Given this list of marker genes PLPP6, CHRNE (cholinergic receptor nicotinic epsilon subunit), PERP, MEP1A, EFCAB6, PRKD3, CTNNA1, SKAP2, KLRG1, CAMKMT, IGF2R, VEGFC, NPFF, MSR1, CLDN12, GFI1 (NCBI Gene Id 2672), SRGAP3, BICD1, RASSF4, OR51B4, REXO5, AQP2, CDKN2B, UBASH3B, OR8A1, HGD, CD244, ODR4, BSCL2, CD96, GATA6, RCN1, TMBIM1, ANXA1, ADRB1, STK17B, PXDC1, COL5A3, RASGRP1, MED7, GOLGA4, A1CF, LIN28A, ATP6V0B, RNF128, CDIPTOSP, SDCBP2, RHOQ, SLC52A3 (NCBI Gene Id 113278), PTGER4, SDK2, ASAH1, CMA1, LRRK1, TEP1, EPDR1, ITGA1, AMIGO1, PXYLP1, LINGO1, RETN, SMARCA2, FHIP1B, ARMC7, RNF148, FGF13, STYK1, CDKN1A, SFI1, DPYD, ITPRIPL2, ST14, SPATA2L, YPEL3, HSD3B1, E4F1, THY1, GPR34, ZBTB38, MOBP, ADGRG5, TMEM63A, OCIAD1, MYADM, YJEFN3, AHSG, YES1, GUCA2B, PRKAA2, GGH, RAB40B, LAPTM5, SERPINE2, CSF1, MGAT4A, FASLG, KCTD11, MFNG, PKP3, COX7A2L, CHIC1, PLEKHO1, ADAM8, TMEM26, PIK3R6, ITGAE, FAT1, BTG1, FCER1G, TMEM163, BCR, GRIA3, GSTT1, LPGAT1, COLEC11, EPAS1, HP1BP3, C19orf12, IPCEF1 (NCBI Gene Id 26034), TMEM140, PRR13, PIK3IP1, CHRNG, GZMH, ENTPD1, GIPC2, FIRRE, FGL2, HID1, DENND3, PTGS1, C4orf54, NECAP1, TFEC, SPESP1, RGS3, SLC22A12, INSYN1, PLCG1, ADAM15, ABI3, CCNG1, IGFBP5, LPP-AS2, ID2, ZEB2, CCR5, RAB12, RESP18 (NCBI Gene Id 389075), CREBRF, FILIP1, CYFIP1, GZMK, PISD, C15orf48, DMRTB1, CCDC106, PICALM, YPEL5, SFXN3, SPACA4, CD109, GNPTAB, CAMK2N1 (calcium/calmodulin dependent protein kinase II inhibitor 1), C9orf152, CD93, AGPAT4, PLIN2, GNG2, GDF11, CCL5, AP3M2, LYVE1, KCTD12, CPEB3, NDRG1, C6, MIR22HG, CITED4, CNRIP1, LIPI, CAPG, ADAMTSL4, TESK1, APOBR, PVT1, LDAF1, PURA, TMPRSS13, ZAP70 (NCBI Gene Id 7535), GLRX, ABCB1, ADCY7, FAXC, ACP3, CFLAR, KCNG1, CNR1, FLOT2, TP53INP2, here is a description of the gene set: Genes down-regulated in comparison of splenic primary CD8 effector T cells at day 8 post-chronic infection versus splenic secondary CD8 effector T cells at day 8 post-chronic infection. Human Gene Set: GSE30962_PRIMARY_VS_SECONDARY_CHRONIC_LCMV_INF_CD8_TCELL_DN species: Homo sapiens Understanding the response of memory CD8 T cells to persistent antigen re-stimulation and the role of CD4 T cell help is critical to the design of successful vaccines for chronic diseases. However, studies comparing the protective abilities and qualities of memory and naïve cells have been mostly performed in acute infections, and little is known about their roles during chronic infections. Herein, we show that memory cells dominate over naïve cells and are protective when present in large enough numbers to quickly reduce infection. In contrast, when infection is not rapidly reduced, memory cells are quickly lost, unlike naïve cells. This loss of memory cells is due to (i) an early block in cell proliferation, (ii) selective regulation by the inhibitory receptor 2B4, and (iii) increased reliance on CD4 T cell help. These findings have important implications towards the design of T cell vaccines against chronic infections and tumors. from publication West EE, Youngblood B, Tan WG, Jin HT, Araki K, Alexe G, Konieczny BT, Calpe S, Freeman GJ, Terhorst C, Haining WN, Ahmed R (PMID 21856186)